The following is a description of a gene set: Human Gene Set: GOBP_REGULATION_OF_NODAL_SIGNALING_PATHWAY Any process that modulates the frequency, rate or extent of nodal signaling pathway. studied in species Homo sapiens, and this is the list of marker genes: NOMO3, DACT2, SHH, NCLN, DAND5, DACT1, DMRT1, NOMO1